Given this list of marker genes Alox5, Duoxa1, Dmd, Rab27a, Sirt1, Foxo3, Zfp13, Ins1, Pikfyve, Letmd1, Clcn3 (NCBI Gene Id 12725), Cybb, Acox1, Abcd1, Park7, Duox1, Abcb7, Il4, Hvcn1, Ppara, Adcy10, Mpo, Fyn, Mpv17l, Ins2, Ncf1, Abcc1, Tlr4, Gbf1, Lipa, Ctns, Cyba, Slc5a3, Cd36, Cyp1a1, Sod2, Ccn6, Alox12, Hbp1, Abcd2, Sphk2, Ptgr1, Cysltr1 (cysteinyl leukotriene receptor 1), Nox4, Grin1, Tlr6, Coa8, Ncf2, Ahr, Mfn2, Duox2, Lcn2, Abcc9, Inava, Rhoa, Stat3, Ndufc2, Hif1a, Duoxa2, Adgrb1 (NCBI Gene Id 97994), Ogt, Hspd1, Prkn (NCBI Gene Id 50873), Slc25a33, Sod1, Ucp1, Cyp1a2, Arg2, Plcg2, Blvra, Hdac4 (NCBI Gene Id 208727), Cflar, here is a description of the gene set: The chemical reactions and pathways resulting in the formation of reactive oxygen species, any molecules or ions formed by the incomplete one-electron reduction of oxygen. Mouse Gene Set: GOBP_REACTIVE_OXYGEN_SPECIES_BIOSYNTHETIC_PROCESS species: Mus musculus